Given this list of marker genes TPD52L1, TLE5, COX17, TBC1D1, KPNB1, ASPH (aspartate beta-hydroxylase), MAPK8, ZIC3, IFT172, TAX1BP1, POLR2I, IFT57 (intraflagellar transport 57), LIX1, PODXL, FGFR1, SLC2A1-DT, SLC15A2, NDUFA1, CHCHD10, SH3BGRL2, NR2F1, TRMT11, PABPC1L, ZMAT1, SYNGR2, MXRA7, PEBP4, PLA2R1, UACA, CPEB4, RAB11A, PPA1, PTGR3, PFKM, PTGDS, NEBL, XIST, TUG1, NDUFA6, NPFFR1, HSD17B7, PLD1, FRZB, MT-CO1, PHACTR2, RANBP1, TRIO, FGF13 (NCBI Gene Id 730528), SLC9B2, MAGI1, UGCG, TMEM106C, TSPAN4, C2CD5, MAGED1, CEP104, GNG11, CXCL14, MOB1B, KTN1, TBC1D9 (NCBI Gene Id 23158), RGN, MT-CO2, CDK5RAP3, WFDC1, RSRC1, PTK7, SHPRH, ATP2C1, TNIK, PCBD2, PALLD, CA2, HSBP1L1, OSBPL1A, TENM1, MRPS28 (mitochondrial ribosomal protein S28), FBXO44, FAM107A, SPART, CRABP1, DENND1B, LCNL1, BOC, POLE4, WNK1, NUDT4, PCSK2, GUK1, HOOK1, SELENBP1, MT-ND4, GPATCH2L, NENF, RELN, DIO3OS, LRRN2, MEGF9, DSP, UQCC5 (ubiquinol-cytochrome c reductase complex assembly factor 5), UQCRQ, here is a description of the gene set: from publication Gautam P, Hamashima K, Chen Y, Zeng Y, Makovoz B, Parikh BH, Lee HY, Lau KA, Su X, Wong RCB, Chan WK, Li H, Blenkinsop TA, Loh YH (PMID 34584087) Occular cell types curated from Gautam and Hamashima et al. Multi-species single-cell transcriptomic analysis of ocular compartment regulons Human Gene Set: GAUTAM_EYE_IRIS_CILIARY_BODY_COL9A1_HIGH_CILIARY_BODY_CELLS studied in species Homo sapiens